Given this list of marker genes Nfkb1, Snai2, Snai1, Akr1c18 (aldo-keto reductase family 1, member C18), Prmt3, Gfi1, Cyp27b1, here is a description of the gene set: Any process that stops, prevents, or reduces the frequency, rate or extent of the chemical reactions and pathways involving a vitamin, one of a number of unrelated organic substances that occur in many foods in small amounts and that are necessary in trace amounts for the normal metabolic functioning of the body. Mouse Gene Set: GOBP_NEGATIVE_REGULATION_OF_VITAMIN_METABOLIC_PROCESS species: Mus musculus